Given this list of marker genes CFI, UNC119, CFH, CFHR3, CFHR1, EFEMP1, APOE, HMCN1, here is a description of the gene set: Drusen (singular, 'druse') are tiny yellow or white accumulations of extracellular material (lipofuscin) that build up in Bruch's membrane of the eye. This class refers to the presence of Drusen in the macula. Human Gene Set: HP_MACULAR_DRUSEN studied in species Homo sapiens Macular drusen